Given this list of marker genes DPYSL2, TMBIM6, PHYH, RGL1, CRIM1, HOMER2, MGLL, GABBR1, CYB5A (NCBI Gene Id 1528), EED, PTP4A3, CSRP1, NEK3, SCN11A, MTX2, NCOA3, CCR7, SQLE, CD81, MRPL35, RARRES1, TPST1, TMEM131L, ARHGAP22, CYP27B1, PLEKHA5, FKBP1B, KMO, ELL3 (elongation factor for RNA polymerase II 3), VDR, IL1R1, LITAF, FZD5, METTL1, MREG, KYNU, TIA1 (NCBI Gene Id 7072), DAPP1, RO60, PLPP1, NETO2, IL10, ZDHHC18, RAB13, MMP9, LMNB1, FCHSD2, SCAMP2, EGLN3, TBCB, FTH1, RAB8B, GCLM, TNIP2, EMC2, SUZ12, MARCKS (NCBI Gene Id 4082), ADAM12, NRP1, ANXA2, RFTN1, GPR137B, TXN, DAD1, TBC1D13, CDKN1A, CXCL9, GFPT1, MPZL1, CD47, TRADD, TNFRSF4, CCL22, ZFYVE16, DNPH1, HDAC2, SPINT2, IRF4, CELF2, IL6ST, CYP1B1, SMARCC1, LMBR1L, CCL18, CRIP1, CD1B (NCBI Gene Id 910), DHCR7, TFG, UBAP2L, PLXNA1, TMEM51, HSPB1, ADAM8, ST3GAL1, EMG1, CD1E, SLC11A2, LHFPL2, FADS1, LPP, RUNX3, CD80, GGH, BCAP31, RAB3GAP1 (RAB3 GTPase activating protein catalytic subunit 1), NIT2, NARS1, TRAF5, BIRC3, ARL6IP5, PDCD6IP, MATK, CCL13, UFSP2, CEP15, DIPK1A, SEPHS1, CD9 (CD9 molecule), APOE, DEPTOR, GBA1, ANXA2P2, FOXJ2, SLC12A8, CCL8, PSMG1, TBC1D4, CXCR4, NET1, RBM47, SLC1A4, TCF3, HSD11B1, SPP1, LRRK1, LAMP3 (NCBI Gene Id 27074), ACP5, NDUFS2, EPB41L2, QPRT, EMILIN1, RAB38, CFLAR, B4GALT5, POGLUT1, MDH1, NR4A3, TFRC, CSF2RA, AKR1C1, IL21R, PVR (PVR cell adhesion molecule), ANOS1, ATP6V1H (ATPase H+ transporting V1 subunit H), CCL17, VAT1, MCM5, MAOA, SERPINF1, ACO1, LTBP2, GRSF1, CIRBP, ALAS1, SLC29A3, CSNK1E, TMEM184C, CD84, LXN (latexin), CYTH1, ATP6V0E1, IL1R2, NDE1, YIPF6, NME3, FILIP1L, GPNMB, CD59, KIF2A, TGM2, MAP3K14, PSD3, MICAL1, SGPL1, MED13L, CD83, CCNG2, BTG1, GOT2, BCOR, MOB1A, PPP1R16B, FNBP1, PLGRKT, DYNC1LI1, NAT1, ZNF274, INHBA (inhibin subunit beta A), IL1A, EBI3, DCSTAMP, IL13RA1, SERPINE1, CCNI, ME1, EEF1AKMT3, CRYZ, GRK3, PSEN2, TMEM97, CLIC2, RER1, GADD45B, DHCR24, MMP12, MED14, LDLR, NDP, FSCN1, PRDX1, RASGRP3, SDC4, PIGP, ST8SIA1, TTN, CERS6, SQSTM1, ACSL3, CREG1, NPC1, FCER1A, PKNOX1, SLAMF8, RAMP1, SYNGR3 (synaptogyrin 3), TUBA1C, STOM, CREBL2, ELOA, SLC5A3, CEP350, ATP1B3, ROBO1, CCL19, RABGAP1, SMS, ATP6V1C1, MARCKSL1, MAP4K4, ADAMDEC1, HLA-DRB4, SLAMF7, DOCK4, CASP3, WNT5B, DNAJB6, GLS, BATF3, CD63, RAB11FIP1 (RAB11 family interacting protein 1), AKT3, TCEAL9, GSDME, N4BP1, GAS6, SLAMF1, LY75, CCSER2, BET1, NECTIN2, SLC3A2, C1S, PPARD, SLC1A2, CD209, APOO, PIR, CDS2, RDH11, CD58, EIF2S1, ENSA, GNA12, OPTN, ABCG1, LPAR1, FASTKD1, NARF, SPRED2, C3orf18, SEC22B, PSMB5, SLC7A11, RUNX1, GM2A, RDX, JAK1, LYPD3, YWHAQ, JAG1, PLPP3, SDC2, ASMTL, NIBAN1, IER5, ILRUN, TNIP3, RAB9A, ST3GAL6, DPAGT1, CD86, SLC1A3, DUSP5, DUOX1, TRIP10, PDE4DIP, TNS3, EIF2B3, SC5D, CEP83, TNFAIP6, LAMP2, ZHX2, CSTF3, TRAF3, GPD2, REPIN1, CCND1, ATP9B, ADAM19, NQO1, TNFAIP8, PPP1R12A, TRAF1, MMP2, CHI3L1, NDRG1 (N-myc downstream regulated 1), APOC1, SCD, MAP3K6, KCNMA1, here is a description of the gene set: from publication Rutella S, Bonanno G, Procoli A, Mariotti A, de Ritis DG, Curti A, Danese S, Pessina G, Pandolfi S, Natoni F, Di Febo A, Scambia G, Manfredini R, Salati S, Ferrari S, Pierelli L, Leone G, Lemoli RM (PMID 16527888) Human Gene Set: RUTELLA_RESPONSE_TO_CSF2RB_AND_IL4_UP Several hematopoietic growth factors, including interleukin-10 (IL-10) and transforming growth factor-beta1 (TGF-beta1), promote the differentiation of tolerogenic dendritic cells (DCs). Hepatocyte growth factor (HGF) is a pleiotropic cytokine whose effects on human DC differentiation and function have not been investigated. Monocytes cultured with HGF (HGFMo) differentiated into accessory cells with DC-like morphology, released low amounts of IL-12p70 and up-regulated IL-10 both at the mRNA and at the protein level. Upon activation with HGFMo, allogeneic CD4+CD25- T cells expressed the T regulatory (Treg)-associated transcription factor FoxP3, proliferated poorly, and released high levels of IL-10. Interestingly, blockade of surface immunoglobulin-like transcript 3 (ILT3) on HGFMo or neutralization of secreted IL-10 translated into partial restoration of T-cell proliferation. Secondary stimulation of HGFMo-primed CD4+ T cells with immunogenic DCs differentiated with granulocyte-macrophage colony-stimulating factor (GM-CSF) and IL-4 from monocytes of the same donor resulted in measurable T-cell proliferation. HGFMo-primed CD4+ T cells significantly inhibited the proliferation of naive CD4+CD25- T cells in a cell-contact-dependent manner. Finally, DNA microarray analysis revealed a unique gene-expression profile of HGF-activated monocytes. Collectively, our findings point to a novel role for HGF in the regulation of monocyte/DC functions that might be exploited therapeutically. Genes up-regulated in peripheral blood monocytes by CSF2RB (GM-CSF) and IL4. species: Homo sapiens